Given this list of marker genes RPL3, CDC40, TGFBR3, SSR1, SEC16A, MAPK1IP1L, SMARCD1, FBXW4, DNASE1L3, IGHG1, WIPI2, CD59, RAC2 (Rac family small GTPase 2), GM2A, PELI1, SELPLG, RNF10, CD4, INPP1, THUMPD2, B4GALT3, DDX41, SERBP1, HSPD1, TAL1, RTF2, IPO9, ADAM8, SLC7A1, SULT1A1, FOXC1, SESN3, BTF3, ENSG00000260937, UBE2L3, JUP, EIF1AX, CYREN, ANAPC16, RAP2C, GGCX, MAT2A, DDOST, IFNA7, PHC3, TBL1XR1, ZNF174, SLC26A9, ARPC2, TAPBP, CACNA1A, RAB8A (RAB8A, member RAS oncogene family), NUCKS1, PIN4, EPOR, IGLC2, EDNRB, RAB26, HLA-A, HLA-DQA1, HMBS, DDX17, PITPNA, SET, SMDT1, PHF20, SLC44A4, PRKCI, LGALS1, CD74, OR3A3, here is a description of the gene set: from publication Liu BH, Goh CH, Ooi LL, Hui KM (PMID 18332864) Low abundance transcripts specific to nasopharyngeal carcinoma (NPC). studied in species Homo sapiens Human Gene Set: LIU_NASOPHARYNGEAL_CARCINOMA Most human cancers are characterized by genetic aberrations accompanied by altered expression and function of numerous genes. Applying genome-wide, microarray gene expression analysis to identify deregulated genes in different tumour types can provide potential gene candidates as diagnostic and prognostic tools and promising targets for drug development. However, the detection of deregulated genes with low levels of expression remains a major challenge. In this study, we have designed a strategy, termed modified suppression subtractive hybridization (mSSH), to identify genes encoding rare transcripts. The strategy entails incorporating the T(7)-promoter sequence at the 5' end of the noncoding cDNA strand during first strand cDNA synthesis to generate unidirectional antisense RNA from the resultant cDNA following conventional SSH. These transcripts are subsequently analysed by Affymetrix oligonucleotide gene arrays. Here, we have used five hepatocellular carcinoma (HCC), five breast carcinoma and four nasopharyngeal carcinoma (NPC) biopsies separately as testers and their corresponding normal biopsies as drivers to enrich for low abundance tumour type-specific transcripts. The total detectable number of probe sets following mSSH was reduced almost 10-fold in comparison to those detected for the same resected tumour tissues without undergoing subtraction, thus yielding a subtraction efficacy of over 90%. Using this experimental approach, we have identified 48 HCC-specific, 45 breast carcinoma-specific, and 83 NPC-specific genes. In addition, genes were upregulated in all the three cancer types. When compared to gene-profiling data obtained without mSSH, the majority of these identified transcripts were of low abundance in the original cancer tissues. mSSH can therefore serve as a comprehensive molecular strategy for pursuing functional genomic studies of human cancers.